The following is a description of a gene set: Prolonged neonatal jaundice species: Homo sapiens Human Gene Set: HP_PROLONGED_NEONATAL_JAUNDICE Neonatal jaundice refers to a yellowing of the skin and other tissues of a newborn infant as a result of increased concentrations of bilirubin in the blood. Neonatal jaundice affects over half of all newborns to some extent in the first week of life. Prolonged neonatal jaundice is said to be present if the jaundice persists for longer than 14 days in term infants and 21 days in preterm infants., and this is the list of marker genes: POU1F1, SLC5A5 (NCBI Gene Id 6528), UGT1A1, TREX1, DUOXA2, GYPC, TSHR, IFT56, PEPD, APC2, NPC2, PEX1, MED12, ATP7A, KMT2D, SPTA1, CDAN1, TPO, RNASEH2B, HESX1, LSM11, SLC10A1, HYOU1, LHX4, RNU7-1, MPV17, TRHR, NKX2-1, AMACR, ARL13B, NSD1, TG (NCBI Gene Id 7038), PKLR, CTCF, TPI1, CCDC115, LHX3, SAMHD1, EPB41, RHAG, SPTB, NPC1 (NCBI Gene Id 4864), RNU4ATAC, GALM, AKR1D1, NKX2-5, SLC37A4, DUOX2, SLC51B, PRPS1, SLC16A2, GALK1, PAX8, UNC45A, IFIH1, PARS2, RNASEH2C, IYD, TBX19, YARS1, RNASEH2A, CASK, SMPD1, GH1, SPOP (speckle type BTB/POZ protein), FOXE1, TSHB, PEX10, SLC26A4, ADAR, CPOX, KMT2E, SLC44A1, CYP27A1, G6PD, JAG1, ATP6AP1, ADAMTS13, PROP1 (NCBI Gene Id 5626)